Given this list of marker genes SBDS, RAC2, EFL1, PMM2, CEBPE, DNAJC21, LCP2, here is a description of the gene set: Human Gene Set: HP_IMPAIRED_NEUTROPHIL_CHEMOTAXIS An impairment of the migration of neutrophils towards chemoattractants as part of the innate immune response Impaired neutrophil chemotaxis studied in species Homo sapiens